Given this list of marker genes MAP3K20, ANKRD28, TFF2, N4BP2L2, OPRM1, CUX2, GTF2I, EME1, ANK2, DCLK1, SEPHS1, ARFIP1, LRIT2, NEO1, KDM5A, NUDT4, ADRB3, EPC2, PURA, EHBP1, RIMBP2, SRSF1, MYL2, LMAN1, ITGBL1, BACE1, CBFA2T3, TM9SF2, OSBPL6, VIM, RTL3, GOLIM4, KATNBL1, CRTC1, MOB1B, ZNF773, CLOCK, CRISPLD1, LPP, RTKN2, RNF19B, SLC9A9, NRP2, CWF19L1, GNAI1, RAPGEF2, ADAMTS17, DBN1, DCX, ACBD3, ASAP2, COLCA1, FBXO3, SEMA6A, XKR4, MEF2C (NCBI Gene Id 4208), HUWE1, SGTB, FAM240A, ZNF146, SYT4, DNALI1, TPH2, SEPTIN10, ZKSCAN7, DNAJB4 (DnaJ heat shock protein family (Hsp40) member B4), FBXW10B, BICD2, FAXC, ONECUT2, PTGFRN, SSR2, CPEB2, PHC1, LAMTOR3, RIMS2, DPP10, WAC, GLOD4, S100Z, CEP20, TBC1D4, SPPL3, ZNF586, SHISA9, CHIC1, KERA, JARID2, FOXA2, GRK5, LRRC28, PREX2, ATOSA, DMAC1, PJA1, DYNC1I1, CTTNBP2NL, LOX, DNAJC12, PTGDR, SRGAP1, BEND4, PRKACB, EFHC2, TNFRSF9, YTHDF3, MTF1, GPR171, LRRTM2, ASXL3, here is a description of the gene set: species: Homo sapiens Human Gene Set: MIR3167 Genes predicted to be targets of miRBase v22 microRNA hsa-miR-3167 in miRDB v6.0 with MirTarget v4 prediction scores > 80 (high confidence targets). from publication Chen Y, Wang X (PMID 31504780)